The following is a description of a gene set: Cancer module 320: M phase. Human Gene Set: MODULE_320 species: Homo sapiens, and this is the list of marker genes: CENPE, KIF23, BRCA1, ZW10, P3H4, RAD21, NCAPD2, KIF11, MID1, NDC80, SMC2, MSH5 (NCBI Gene Id 4439), RAN, DDX11, PTTG1, ESPL1, ILF3, MAPT, TTK, CCNA1